The following is a description of a gene set: Mouse Gene Set: chr17A2 species: Mus musculus, and this is the list of marker genes: Gm3222 (predicted pseudogene 3222), Psmb1, Rgmb, Gm23352, Gm7177, Gm7356, Ermardl1, Wdr27, Gm3292, Gm7450, Pdcd2, Gm34567, Gm6686, Gm35576, Gm7423, Prdm9, Gm7358, 1600012H06Rik, Dact2, Thbs2, Smoc2, 4933401D09Rik, Gm38551 (NCBI Gene Id 102641363), Gm5091, Chd1, 4930474M22Rik, Gm49668, Tbp, 4930488N24Rik, Dynlt2a1, Gm7168, Gm34510, Ermard, Eif3s6-ps3, Dll1, Gm35455, Dynlt2a2, Dynlt2a3, Phf10, Fam120b, Ermardl2, Gm3507, Gm18564, Gm7393